Given this list of marker genes ZNF493, COX8C, POLR2J, ZNF317, TXNIP, TFDP1, MAPKAPK5, CBFB, NCBP2, PCGF2, LSM10, ZNF577, RNU4ATAC (NCBI Gene Id 57788), NRBF2, SRRM1, BRIP1, ZNF735, GSR, MED30, H2AC20, ZNF429, ZSCAN25, HEY2, ZNF45, CALM1, ZNF616, TBL1X, MAF, SMURF2, GEM, ZNF264, GADD45A, MLLT3, POLR2L, ZNF160, BRCA1, H2BC5, TNFRSF10B, H2BC6, POLR2K, ELOA, OCLN, GATA3, CENPJ, ZNF416, CCNE2, TMEM219, CDC7, PVALB, CDC73, MED23, TAF3, RNU12, ZNF157, KRBOX4, ZNF263, ZNF589, ZNF420, SRRT, ZNF607, SMAD4, PRDM1, ERCC2, SKP2, ZNF34, CGB3, CNOT2, BAX, ZNF418 (zinc finger protein 418), CTSV, NELFA, BRD1, ZNF510, RABGGTA, ZFP28, USP2, RNU5A-1, PLAGL1, STAT1, CBX3, ZNF613, CASP6, POU2F2 (NCBI Gene Id 5452), COX5B, TWIST1, WDR33, GATA2, ASH2L, THOC2, ZNF571 (zinc finger protein 571), TSC2, H2BC9, HDAC5, ZNF680, ZNF25, TNRC6A, CGB5, ATXN3 (ataxin 3), EPC1, ZKSCAN8, NFYC, PRKAA1, KLF4, MT-CO1, CSTF2, BLK, SPI1, RXRA, ZNF138, RPA1, USP7, SUMO1, ZNF573, ZNF135, BLM, ZKSCAN4, TOPBP1, NPAS4, ZNF729, NCBP1, STUB1, ZNF440, COX7A1, RBPJ, CSNK2B, ZNF777, ZNF140, ZNF41, PRDM7, ZNF385A, CITED4, CAMK2A, TFAP2D, ZNF570, TCF7L1 (NCBI Gene Id 83439), ELF1, POLDIP3, H2AJ, SKI (SKI proto-oncogene), E2F1, AKT1, E2F8, ZNF300, ANAPC15, AGO3, MIR137, ZNF473, PSMC1, SMARCC1, ZNF500, NDRG1, EP300, SNRPE, H3C8, MAML1, H4C8, ZNF33B, TNFRSF10C, MED7 (mediator complex subunit 7), TAF5, PIP4K2A, CSTF3, ZNF425, PRKAG3, ATR, H2AC18, ELOB, SMARCB1, FANCI, ZNF79, ZNF551, ZNF561, ANAPC10 (NCBI Gene Id 25866), PSMA4, TRPC3, PTPN11 (protein tyrosine phosphatase non-receptor type 11), BRPF1, CLDN5, ZNF461, ACTL6B, ZNF587, CYCS, SCMH1, ZNF677, FAS, ELL, YES1, RFC2, PRMT6, ZNF311, ZC3H8, ZNF468, ZFP1, PMAIP1, ZNF483, GTF2H3, MAPK3, CEBPB, POU4F1, PSMC5, FOS, ZNF705D, ZNF552, H3C2, ZNF436, PPP1R13B (protein phosphatase 1 regulatory subunit 13B), ADRM1, ZNF655, NR3C2, ZNF569, ZNF726, CITED1, PSMB7, HDAC1, AGRP, LSM11, NOTCH1, GTF2H2, PRKCB, TNFRSF18, PRKAB2, MEAF6, ZFP2, RRAGB, TXNRD1, ZNF605, RBFOX3, ZNF266, DGCR8, HTT, ZNF112, MDC1, PBRM1, PINK1, SERPINB13, ZNF705EP, LGALS3, SMARCA4, TRIM33, PRKCQ, BTG2, ZNF540, CBX5, ZNF205, EAF2, MECP2, YBX1, CDK12, ZNF274, ZNF155, IL3, ZNF136, H4C3, MED4, AGO4, BCL6, NR1I3, TCF7L2, NR2E1 (NCBI Gene Id 7101), CREBBP (CREB binding protein), ZNF74, NR4A2, INS, SMAD3, MAPK14 (mitogen-activated protein kinase 14), FOXO1, PPM1A, ZNF568, INTS2, ZFPM1, IL2, CCNT2, PRDX5, TBP, SRSF11, MEF2C, ZNF597, ZNF626, ZNF839, ZNF286A, INTS3, MAPK11, COX4I2, E2F6, MED16, PCK1, CAV1, NR5A1, TPX2, ZFP30, ZNF563, SIRT3, MOBP, CDK8, MIR24-2, FYTTD1, INTS9, GATA4, PPP2R1B, PPP1R13L, ABCA6, DLL1, ZNF562, TEAD4, E2F5, POLR2H, IHH, NDUFA4, PSMC4, ZNF774, ZNF225, THOC6, ZNF415, NR1H3, CDK7, ZNF23, ZNF382, ZNF197, ZNF582, ZNF697, DAXX, ZNF746, RRM2B, MRE11, ZNF556, THBS1, CDK6, TWIST2, H4C4, ZNF558, TFAP2A, GPRIN1, PRKACA, TRIAP1, HAND2, SETD1B (NCBI Gene Id 23067), CGB8, CPSF7, NKX2-5, ZNF431, GTF2F2, LDB1, ZNF496, ANAPC7, MEN1, CASP1, FASLG, FKBP5, SMARCD2, H2BC11, RORC, ZNF689, YEATS4, ZNF667, H2AC8, ZNF727, ZNF681 (zinc finger protein 681), KAT6A, CCNK, RELA, ZNF17, SRSF1 (serine and arginine rich splicing factor 1), H2BC17, ZNF33A, UBE2I, COX5A, MDM4, DDIT4, SLBP, NR4A1, RRAGD, HDAC11, FANCC, NR0B2, TJP1 (NCBI Gene Id 7082), TNRC6C, PIN1, AGO1, PRKAG1, AFF4, SGK1, UBC, KMT5A, CNOT7, ZNF383, PCGF6, STK11, ZNF430, TIGAR, ESR2, PDPK1, ZNF705G, POMC, ZNF676, BID, SOX2, POLR2D, SETD9, HDAC8, CNOT1, HDAC4, NELFE, ZNF337, HDAC2, ING5, CCNB1, RRM2, PCGF5, CCND2, TFAP2B, JUN, ZNF799, PAX5, H2AZ2, NR5A2, PSMA6, HEY1, MAX, ZNF114, RORB, MYL9, JUNB, SRSF5, CDK2, CSTF1, LBR, ZIM2, RBFOX1, EIF4A3, CASC3, ZNF585A, ZNF682, NR6A1, CPSF3, H2AX (H2A.X variant histone), FOXP3, CSTF2T, ESRRG, MIR27A, H4C16, PHC3, ZNF555, YY1, SREBF1, SMAD6, MED24, ZNF688, TP53, ZNF28, FBXO32, CNOT4, ZNF343, SUPT6H, MAML2, ZNF770, ZNF530, AGO2, PERP, ZNF354C, LUZP4, PSMD1, CTNNB1, ZNF664, ATRIP, ZNF521, ZNF778, ZNF282, U2AF1, CASP2, RPAP2, G6PD, ZNF714, ZNF417, BCL2L14, PRELID1, MAGOHB, RUNX2, NCOR1, SERPINE1, ZNF764, BARD1, PSMD6 (NCBI Gene Id 9861), AUTS2, TEAD2, POLR2E, IFNG, STEAP3, RBBP4 (NCBI Gene Id 91125), YWHAE, ZKSCAN3, TNFRSF10D, NUDT21, TP53RK, GTF2B, OPRM1, YWHAZ, CCN2, SYMPK, COX6A1, FOXO6, ZNF606, YWHAG, H4C5, TAF13, NBN, HIPK2, UPF3B, PSMA2, AURKA, RNPS1, TGIF1, KRAS, ZNF14, YAF2, HDAC9, FZR1, CSF2, ZNF184, MBD3, CR1, SRC, PTPN4, ZNF627, RBBP5, ZNF614, CPSF2, ZNF554, TAF9B, H2BC7, ZNF37A, CAMK2D, GTF2E2, E2F7, INTS8, MED20, SSRP1, UCMA, BMAL1, EGFR, ZFP69B, ZNF200, SLC38A9, TAF7L, MGA, AIFM2, ZKSCAN5, MED12, TP53INP1, ZNF615, ANAPC1, ZNF678, ZNF662, RICTOR, SUZ12, NCOR2, ARID2, ATF2, PML, ZNF529, ZNF398, ZNF514, CCND3, H2BC12, ZNF669, ZNF738, SFN, ZNF202, H3C7, ZNF785, TOP3A, TP73, SMAD1, ZNF684, MAPKAP1, NELFB, TAF2, LAMTOR5, CDC16, SKIC8, ZNF710, EXO1, SIN3B, RBM8A, POLR2A, ITGAL, PSMD3, ZNF26, ZNF212, RPRD2, RBM14, ZNF711, PHF20, ZNF670, ZNF708, SRSF2, NR1H2, BIRC5, MSTN, SRF, RNU4-1, ZNF43, ZNF567, ZNF486, YWHAB (tyrosine 3-monooxygenase/tryptophan 5-monooxygenase activation protein beta), ZNF254, GCK, ELF2, INTS1 (integrator complex subunit 1), ZNF625, NUAK1, MYBL2, ZNF235, LAMTOR3, ICE1, GAD2, ZNF790, PSMC3, PTEN, THOC3, DPY30, SOCS3, CHM, ZNF100, ZNF92, G6PC1, KAT2A, ZNF445, ZNF560, BANP, INTS7, ZNF334, ZNF446, H2BC1, UBE2D3 (NCBI Gene Id 7323), ZNF285, ZNF782, RAD50, ARNT, PSMD11, KAT2B, RAD9A, ZNF621, ZNF233, SNRPD3, ZNF671, NPY, DHX38, TGFB1, ZNF211, SRSF4, ZNF713, PSMA3, RPA2, TCEA1, ZNF490, ZNF665, H3-3B, CITED2, RRAGA, ZNF324, CNOT3, ZNF550, AR, CNOT10, COX7C, NOTCH2, ANAPC2, ZNF793, H3C15, PPP2CA, ZNF860, YWHAH, CREB1, ZIM3, CHD3, PIP4K2C, ZNF549, GPX2, DLX6, PSMD14, GTF2H5, ZNF506, RBBP8, RUNX3, CSNK2A2, HDAC7, CCNG1 (NCBI Gene Id 900), BMI1, CDK5R1, COL1A1, MTOR, ZNF660, DDB2, SIN3A, KCTD6, COX7B, ZNF208, RBBP7, UBE2S, ZNF470, ELOC, WDR5, ESRRB, PLXNA4 (plexin A4), SMARCC2, BCL2L11, CBX4, NFKB1, MIR132, GTF2E1, CNOT6L, ABL1, PSMA5, CDC27, OPRK1, SMAD2 (SMAD family member 2), ZFP90, IL2RA, HDAC6, ERCC3, MSX2, INTS14, CDKN2B, NR1I2, ZNF557, NR2F6, ZNF492, ZNF287, RETN, RMI1, RUNX1 (RUNX family transcription factor 1), ZNF703, PSMD13, ZNF250, ZNF354A, SLC2A3, MOV10, SRSF9, H3C6, ZNF143, CDK4 (cyclin dependent kinase 4), ZNF442, BGLAP, RB1, MMP13, KMT2A, WWTR1, H3C11, MET, CPSF6, ELL2, RNMT, SESN2, DYRK2, GLS, PABPN1, NR1D2, CARM1, RPRD1B, RFFL, COL1A2, GTF2A1, ZNF696, SNAPC1, WWP1, ZNF707, EHMT2 (euchromatic histone lysine methyltransferase 2), MDM2 (NCBI Gene Id 84825), RAD51D, H3C10, NFATC2, RBL1, THOC7, KCNIP3, RXRB, H2BC10, SKP1, SETD1A, MYB, CRADD, SNAPC2, ZNF227, SMARCD3, SUPT5H, SUPT16H, ZNF214, ZNF226, NR1H4, BTG1, SMARCD1, CGA, PPP2CB, ZNF747, ZNF350, ZNF716, SNRPF, CNOT9, LMO2, ZNF721 (zinc finger protein 721), H2BC4, INTS13, ZNF724, MED25, CTDP1, ZNF732, ZNF704, MLST8, MED13, H3C3, ARID3A, H4C2, MED14, NR2E3, ANAPC16, NEDD4L, CBX2, ZNF480, ZNF528, AURKB, SP1, NLRC4, COX6B1, NABP1, ITCH, ZNF215, SNRPB, ACTL6A (NCBI Gene Id 9178), COX7A2, CDKN2A (NCBI Gene Id 1029), TAF1L, H2AC14, HSPD1, ITGA4, PSMC2, ZNF253, CCNG2 (cyclin G2), CDC23, TCF3, CTSK, CAMK2G, MED8, TFAP2C, ZNF479, ZNF10, CHD4, ZNF668, ARNT2, MED26 (mediator complex subunit 26), ZNF75D, SMARCA2, GPAM, ZNF740, PPARD, UBE2C, MED15, H2BC12L, NR3C1, RPRD1A, BRPF3, CCNC, LEO1, ATM, POU2F1, H3C14, GPS2, IGFBP1, GRIA2, ZKSCAN1, RABGGTB, WRN, RPS27A, VEGFA (NCBI Gene Id 7422), ZNF30, ZNF544, POLR2I, GATA1, ZNF304, NR2F1, MAGED1, ZNF543, GLS2, HIVEP3, CSNK2A1, PIP4P1, BBC3, CTR9, SARNP (NCBI Gene Id 84324), ZNF439, H2AC4, PRKAG2, TAF8, TBX5, RNF34, COX4I1, PHC1, TBL1XR1, TAF7, SKIL, CCNH (cyclin H), HIPK1, TEAD3, H4C1, H2BC14, ZNF692, ZNF99, SMAD7, TNKS1BP1 (NCBI Gene Id 85456), POLR2F, SNW1, ZNF565, PARP1, MED1, CAMK4 (NCBI Gene Id 814), GLI2, ATP1B4, PSMD12, CCNT1, ZNF2, SEM1, H2BC3, CBX8, GTF2H1, PRELID3A, HDAC10 (NCBI Gene Id 83933), ZNF441, PSMB5 (proteasome 20S subunit beta 5), ZIK1, ZNF517, RRAGC, ZFP69, ZNF19, NR0B1, ZNF620, ZNF20, ZNF273, TAL1, H4C14, PRMT1, BRD7, PRKAA2, ZNF221, PAPOLA, BRD2, CDC40, PPP2R5C, SRSF3, PF4, ZNF730 (zinc finger protein 730), H2BC13, ING2, UBB, HDAC3, ZNF718, TP53I3, TGIF2, ZNF234, ZNF699, ZNF223, ZNF564, H4C9, ITGA5, MED31, TAF6, YWHAQ, ZNF213, COX7A2L, KIT, BNIP3L, CPSF1, ICE2, POLR2B, SP7, DEK, TFAP2E, RNU2-1 (RNA, U2 small nuclear 1), SNAPC3, ZNF426, PSMD7, HNF4G, TAF1 (NCBI Gene Id 6872), RSPO3, CDKN1B, PHAX, CAMK2B, PRMT5, ESR1, CLP1, PLK2, ITGA2B, BMP2, TP53BP2, TAF12, ZNF737, USP9X, RXRG, H2BC8, ZNF583, CNOT6, ZNF70, RING1, RBX1, KMT2D, ZNF124, ARID1A, H2AC7, GRIN2A, NFYB, GSK3B, POLR2G, ZNF566, PRDX2, ZNF599, RTF1, PSMB2, ZNF75A, RAD17, ZNF484, TSC1, CRH, EAF1, GTF2H4, RBL2, RNF111, CTLA4, MTA2, ZNF175, ZNF736, CDK13, SESN3 (NCBI Gene Id 143686), NR4A3, AKT2, ZNF12, ZNF169, CDC25C, ZNF302, ZNF432, TFDP2, RAD51, ZNF268, IL6, COX6B2, GTF2A2, ZNF454, KCTD1, FOXO3, PCF11, ZNF230, PSMD8, ZNF18 (NCBI Gene Id 7566), H2AC19, HUS1, TAF9, E2F4, NR1D1, H4C11, SRSF7, EHMT1, RHNO1, ZNF267, L3MBTL1, RPTOR, H2AC6, CHEK2, ZNF548, PLK3, SOX9, INTS4, RET, H4C12, RFC4, FANCD2, ZNF595, ZNF773, TXN, ZNF701, ZNF248, MIR24-1, ZNF320 (zinc finger protein 320), ZNF761, BDNF, TAF15, CPSF4, CDK5, WWOX, UBE2D1, ZNF649, SLU7, L3MBTL2, H2BC21, NOTCH3, ZNF776, POLR2C, SUPT4H1, TRIM63, NOP2, PSMB1, PIDD1, CTSL, UBA52, RPA3, HNF4A, KRBOX5, ZNF547, ZNF324B, TCF12, RGCC, ZNF331, GLI3, H3C13, H2BC15, GPI, NKX3-2, TAF4B, ZNF804B, KDM5B, H3C1, RMI2, ZNF586, GRIN2B, ZNF433, UXT, TNFRSF10A, DDIT3, PPARG, ZNF772, IWS1, ZNF189, PRR5, ZNF786, DDX39B, CNOT8, SPP1, ZNF700, RYBP, SIRT1, ZC3H11A, LAMTOR2, LAMTOR1, MLH1, HIGD1C, VENTX, TGFA, TP63, NOC2L, NRBP1, MAP2K6, NFYA, H3C4, H4C15, ZNF347, CDC26, PPARA, ZNF154, ZNF775, U2AF1L4, ZNF705A, ZNF641, ZNF471, SNRPG, SRSF6, THRB, ZNF485, TRIM28, INTS12, ESRRA, MED6, ZNF354B, ZNF584, CHEK1, CCNE1, INTS5, U2AF2, PRKAB1, KAT5, SATB2, ZNF791, ANAPC4, AKT3, ZNF195, JAG1, ZNF77, CDK9, RNU1-1, NOTCH4 (notch receptor 4), CSF1R, RARG, SMYD2, PPARGC1B, PSMB4, GAD1, ZNF101, MYC, ZNF771, INTS11, NAMPT, PSMB3, ZFP14, ANAPC5, FURIN, ERBB2, ZNF709, PIP4K2B, NR2C2, CNOT11, H3-3A, SESN1, TAF10, TEAD1, ZNF257, INTS10, IQSEC3, APAF1, ZNF611, ZNF750, SMURF1, LIFR, CDK1, NPM1, VDR, ZNF717, ZNF224, IRAK1, COX6A2, H3C12, COX8A, KMT2B, NFE2, CAT, ZNF619, ZNF679, SYT10, POU4F2, MT-CO2, ZKSCAN7, ZNF749, GAMT, ZNF141, MSH2, IGFBP3, ZNF222, ITGBL1, SST, GATAD2B, LEF1, ZNF256, ZFHX3, SOCS4, CCND1, ARID1B, ZNF792, ZNF333, UBE2E1, FIP1L1, TNRC6B, SOD2, NR2C2AP, THOC5, RFC3, ZNF691, ZSCAN32, RNGTT, H2AB1, ZNF875, GTF2F1, MAPK1, ZNF519, ZNF71, ZNF675, ZNF460, NR2C1, KMT2C, CHTOP, KRBA1, PSMB6, PITX2, THOC1, PPP2R1A, RARB, LMO1, DLX5, CCNA2, MED10, PPARGC1A, GATAD2A, ELL3, ELOA2, ALYREF, ATAD2, FOXO4, ZNF585B, RAD1, RHEB, MNAT1, MAML3, ANAPC11, JMY, THRA, ZNF133, DDX39A, NPPA, APOE, EZH2, FOXG1, ZNF419, TTC5, PCNA, CASP10, PRDX1, CBX6, ZNF624, PPM1D, HES1, KCTD15 (potassium channel tetramerization domain containing 15), RAD9B, TAF11, SNAPC5, INTS6 (integrator complex subunit 6), PTPN1, MED17, PCBP4, MAMLD1, TCF7, PAF1, ZNF559, MLLT1, H4C13, MT-CO3, PSMD2, ZNF180, H4C6, SSU72, PSMA1, H2BC26, ZNF3, MAGOH, ZNF600, SNAPC4, SMARCE1, GP1BA, LAMTOR4, EED, XPO1, SCO2, CUL1, ZNF546, TAF4 (TATA-box binding protein associated factor 4), PMS2, PHC2, REST, RNU11, PGR, CDKN1A, AXIN1, PSMA7, ZFP37, ZNF596, ZNF394, CCNA1, ZNF658, DNA2, RORA, ZNF443, YAP1, MED27 (NCBI Gene Id 9442), NABP2, RFC5, TP53AIP1, RARA, PSMC6, NELFCD, ZNF706, COX6C, ZNF610, RNF2, here is a description of the gene set: studied in species Homo sapiens RNA Polymerase II Transcription Human Gene Set: REACTOME_RNA_POLYMERASE_II_TRANSCRIPTION